Given this list of marker genes INTU, IFT27, TMEM216, FAM149B1, PDE6D, TOPORS, HOXD13, OFD1, TMEM231, GLI3, KIAA0753, KIF7, TCTN3, CPLANE1, NEK1, here is a description of the gene set: Y-shaped metacarpals are the result of a partial fusion of two metacarpal bones, with the two arms of the Y pointing in the distal direction. Y-shaped metacarpals may be seen in combination with polydactyly. species: Homo sapiens Y-shaped metacarpals Human Gene Set: HP_Y_SHAPED_METACARPALS